The following is a description of a gene set: Human Gene Set: BILD_CTNNB1_ONCOGENIC_SIGNATURE The development of an oncogenic state is a complex process involving the accumulation of multiple independent mutations that lead to deregulation of cell signalling pathways central to the control of cell growth and cell fate. The ability to define cancer subtypes, recurrence of disease and response to specific therapies using DNA microarray-based gene expression signatures has been demonstrated in multiple studies. Various studies have also demonstrated the potential for using gene expression profiles for the analysis of oncogenic pathways. Here we show that gene expression signatures can be identified that reflect the activation status of several oncogenic pathways. When evaluated in several large collections of human cancers, these gene expression signatures identify patterns of pathway deregulation in tumours and clinically relevant associations with disease outcomes. Combining signature-based predictions across several pathways identifies coordinated patterns of pathway deregulation that distinguish between specific cancers and tumour subtypes. Clustering tumours based on pathway signatures further defines prognosis in respective patient subsets, demonstrating that patterns of oncogenic pathway deregulation underlie the development of the oncogenic phenotype and reflect the biology and outcome of specific cancers. Predictions of pathway deregulation in cancer cell lines are also shown to predict the sensitivity to therapeutic agents that target components of the pathway. Linking pathway deregulation with sensitivity to therapeutics that target components of the pathway provides an opportunity to make use of these oncogenic pathway signatures to guide the use of targeted therapeutics. species: Homo sapiens Genes selected in supervised analyses to discriminate cells expressing activated beta-catenin (CTNNB1) oncogene from control cells expressing GFP. from publication Bild AH, Yao G, Chang JT, Wang Q, Potti A, Chasse D, Joshi MB, Harpole D, Lancaster JM, Berchuck A, Olson JA Jr, Marks JR, Dressman HK, West M, Nevins JR (PMID 16273092), and this is the list of marker genes: MAPKAP1, TAF1D, LUZP1, MED31, RBM25, FOXQ1, SORL1, KATNBL1, SMG1, HIPK2, BAMBI, CLN8, PHACTR2, CHD9 (NCBI Gene Id 80205), URB1, TNFAIP3, SECISBP2, PNISR, PLEKHA1, KAZN, AXIN2, SREK1, PLAGL1, COL8A2, FERMT1, ZMAT3, SRSF6, KHNYN, LARP4B, BOD1L1 (biorientation of chromosomes in cell division 1 like 1), NR3C1, FRYL, VCAN, QKI, ELF1, TMCC1, IGLVIVOR22-1, MIRLET7BHG, DYNC1H1, ASH1L, IL1A, KDM4B, DDX52, FAM120A, FLNB, ATRX, ZNF703, DDR2, COL13A1, SCAF11, KRTAP2-3, NCOA3, DHX36 (NCBI Gene Id 96337), NEMF, ARL5A, SBSPON, DUSP5, GNG12, FBXO11, SRSF10, ZNF532, LATS2, WASHC4, ARHGAP29, CYP24A1, NEK1, RUNX2, SMC3, LRBA, CBX3, EPRS1, TOP1, THOC2, ABI2, PIK3C2A, PTHLH, SCML1, TRIM14, FGD6